Given this list of marker genes RNF13, PLEC, ITGB4, OCRL, CRB2, here is a description of the gene set: Elevated maternal circulating alpha-fetoprotein concentration Human Gene Set: HP_ELEVATED_MATERNAL_CIRCULATING_ALPHA_FETOPROTEIN_CONCENTRATION studied in species Homo sapiens Increase in the levels of maternal serum alpha-fetoprotein levels during pregnancy.